The following is a description of a gene set: species: Mus musculus Mouse Gene Set: GOBP_GLYCOSIDE_TRANSPORT The directed movement of a glycoside into, out of or within a cell, or between cells, by means of some agent such as a transporter or pore., and this is the list of marker genes: Ralbp1, Abcb1a, Abcc2, Slc50a1, Slc5a2, Slc5a1, Abcc3